Given this list of marker genes Lbr, Sin3a, Mecp2, Hdac1, Hipk2, here is a description of the gene set: Mouse Gene Set: REACTOME_TRANSCRIPTIONAL_REGULATION_BY_MECP2 Transcriptional Regulation by MECP2 studied in species Mus musculus